The following is a description of a gene set: from publication Chen Y, Wang X (PMID 31504780) Human Gene Set: MIR4716_3P Genes predicted to be targets of miRBase v22 microRNA hsa-miR-4716-3p in miRDB v6.0 with MirTarget v4 prediction scores > 80 (high confidence targets). species: Homo sapiens, and this is the list of marker genes: PTPRJ, SRSF2, CTNND1, ALDH7A1, EFNB1, PPP2R2D, SPRY4, CPM, STXBP4, NUP50, XBP1, ATF7, RAD51B, APOLD1, SFXN3, SUMO2, DEDD, BCL9, SLC22A23, PHLPP1, TRNP1, ACOX1, ZNF395, MVB12B, ZNRF2, PRUNE1, LPGAT1, KAZN, ELP5, TRAF4, EPB41L1, LZTS1, PDX1, USP54, RLBP1, DOCK3, SLC12A6, CSDE1, ESR1, KALRN, MAB21L2, ONECUT2, LDB1, NOVA2, MAN1A2, IL18BP, MAMDC2, HOXB3, RASL11B, CADM1, PTPRS, PXYLP1, MIDEAS, CHD6, UBAP2L, SRF, RAG1, ZBTB20, STC1, APPL1, PPP2R1A, AP3B1, TGFBI, PCM1, GPR137, SESN3, NECTIN1, ASAH1, LARP1, CBX5, RAB2B, ERVFRD-1 (endogenous retrovirus group FRD member 1, envelope), IL17D, RAB14, KLHL13, ARSK, FAM222A, REEP1, RALGPS1, NCAPH2, FAM222B, DAPP1, HGF